The following is a description of a gene set: Mouse Gene Set: GOBP_REGULATION_OF_NEUTROPHIL_CHEMOTAXIS species: Mus musculus Any process that modulates the frequency, rate, or extent of neutrophil chemotaxis. Neutrophil chemotaxis is the directed movement of a neutrophil cell, the most numerous polymorphonuclear leukocyte found in the blood, in response to an external stimulus, usually an infection or wounding., and this is the list of marker genes: Xcl1, Ccl21f, Dysf, Ccl19-ps3, Mdk, Cd74, Tnfaip6, Il23a, Ccl19-ps4, Ccl21b, Tirap, Ccl21a, Ccl19-ps6, Dnm1l, Dapk2, Thbs4, Nckap1l (NCBI Gene Id 78813), Lbp, Rac1, Slit2, C5ar1, C1qbp, Ccl19, Ripor2 (NCBI Gene Id 76622), Cxcr2, Jam3, Ccl19-ps1, C3ar1, Rac2, Il1b, Ccr7, C5ar2, Ccl21e, Mospd2, Nod2, Edn1, Ccl19-ps5, Dpp4, Sell, Mpp1, Ccl21d, Bst1, Camk1d, Perp, Mcu, Ednra